The following is a description of a gene set: species: Homo sapiens CD8+ T cells play a crucial role in the clearance of intracellular pathogens through the generation of cytotoxic effector cells that eliminate infected cells and long-lived memory cells that provide enhanced protection against reinfection. We have previously shown that the inhibitor of E protein transcription factors, Id2, is necessary for accumulation of effector and memory CD8+ T cells during infection. Here we show that CD8+ T cells lacking Id2 did not generate a robust terminally-differentiated KLRG1hi effector population, but displayed a cell-surface phenotype and cytokine profile consistent with memory precursors, raising the question as to whether loss of Id2 impairs the differentiation and/or survival of effector-memory cells. We found that deletion of Bim rescued Id2-deficient CD8+ cell survival during infection. However, the dramatic reduction in KLRG1hi cells caused by loss of Id2 remained in the absence of Bim, such that Id2/Bim double-deficient cells form an exclusively KLRG1loCD127hi memory precursor population. Thus we describe a role for Id2 in both the survival and differentation of normal CD8+ effector and memory populations. Genes up-regulated in KLRG1 low CD8 T effector cells during infection: wildtype versus BCL2L11 knockout. Human Gene Set: GSE41978_WT_VS_BIM_KO_KLRG1_LOW_EFFECTOR_CD8_TCELL_UP from publication Knell J, Best JA, Lind NA, Yang E, D'Cruz LM, Goldrath AW (PMID 23325888), and this is the list of marker genes: CCDC175, SLC35A5 (solute carrier family 35 member A5), GOLPH3, PCNP, GRIA1, ASPH, SFTPC, DLX1, CC2D1A, TMEM230, IFFO1, RBM15B, SLC7A2, LDB3, TCL1A, SLC46A3, FCGR1A, SEMA4A (semaphorin 4A), BHLHA15, SVEP1, CTNNA2 (NCBI Gene Id 1496), ACTR6, ARL2, VPS72, UGGT2, CTC1, PRKCE, CDA, LMNA (NCBI Gene Id 7816), ATP1A2, SLC6A2, ZCCHC3, CIDEC, PDPN, HOXD3, STYX, IGFBP5, SPSB2, NOTCH1, CUEDC1, COX15, GRK1, APOF (NCBI Gene Id 319), RUNX2, ZNF746, GPRC5C, DNAJC18, CPXM2, VSX2, ALDH3B1 (aldehyde dehydrogenase 3 family member B1), CD34, DR1 (NCBI Gene Id 1810), GATAD2A, NLRP6, MOSPD2, POLR2M, HYAL3, SLC39A3, FOLR2, IL12A, NHEJ1, SLC22A25, RHEBL1, STK32B, DMTF1, MYH14, DRAM1 (NCBI Gene Id 55332), TCAF2, SGCB, CCDC90B, PHKA2, SLC25A35, VPS39, TMEM106C, CHAC1, ENPP3, ADGRL4, ALS2, NUP42, LY6H, CDHR5, PTGR1, ZNF276, GLRA1, CAMK1G, IL1B, CDH11, SFI1, INMT, CATSPER2, CD1D, DMTN, GP1BB, SPINT2, TMCO5A, MAB21L2, KIAA1217, DSCAM, HSPB7, CHEK2, MUC15, MYH8, NPY5R, SPAG5, VPS37A (NCBI Gene Id 23687), RFTN2, ZNF346, F2, FAM3B, C11orf16, HAUS2, ECHS1, SPPL2A, ATP6V1G2, TRIT1, LYN, WNT10B, SAMD4B, ELOVL2, TECTB, BCL7C, NNMT, RARG, CPNE3 (NCBI Gene Id 8895), AR, PDE6B, TET1, CLCN2, TAS2R4, LRRIQ4, FAHD1, LRRC61, FAM110C (family with sequence similarity 110 member C), ZBTB7B, HCK, PLEKHN1, CLEC4E, FPR2, XIRP1, KLC2, TMEM131L, ADGRF1, MSL1, PPP1R1A, SNTB1, DNAL4, CXCL3, SPTBN2 (spectrin beta, non-erythrocytic 2), NFATC2IP, FZD5, AXL, PPP1R37, GCDH, FCRLA, TBATA, MAP7D1, ACOX2, UGT2B4, DEPDC1, VEGFD, FZD2, SEL1L2 (SEL1L2 adaptor subunit of SYVN1 ubiquitin ligase), HCN2, TRIP10, DEF8, GLRX2, PLPP3, ADI1, CRB3, ST8SIA4, GPR35, SERPINB2, PCDHB2, DENND2B, XRCC1, KRT34, CASP14, CLEC6A, PPT1, VMP1, S100A3, SMARCD1, PRR12, ABCA1, GPATCH2, KRCC1, PLCD1, PAF1, SOX3, HACD1, TCF15, ASCL3, MPEG1, RAB3IL1, FAM53C, C22orf23, SLC12A9, POF1B, DECR2, FANCE